Given this list of marker genes Mri1, Mtap, here is a description of the gene set: Reactome Pathway: Methionine salvage pathway species: Mus musculus electronically inferred by orthology from the curated human pathway part of: Sulfur amino acid metabolism This event has been computationally inferred from an event that has been demonstrated in another species.<p>The inference is based on the homology mapping from PANTHER. Briefly, reactions for which all involved PhysicalEntities (in input, output and catalyst) have a mapped orthologue/paralogue (for complexes at least 75% of components must have a mapping) are inferred to the other species.